The following is a description of a gene set: A SWI/SNF-type complex that is found in neural stem or progenitor cells, and in human contains actin and proteins encoded by the ARID1A/BAF250A or ARID1B/BAF250B, SMARCD1/BAF60A, SMARCD3/BAF60C, SMARCA2/BRM/BAF190B, SMARCA4/BRG1/BAF190A, SMARCB1/BAF47, SMARCC1/BAF155, SMARCE1/BAF57, SMARCC2/BAF170, PHF10/BAF45A, ACTL6A/BAF53A genes. The npBAF complex is essential for the self-renewal/proliferative capacity of the multipotent neural stem cells. Human Gene Set: GOCC_NPBAF_COMPLEX species: Homo sapiens, and this is the list of marker genes: ACTB, ARID1A, ACTL6A, SS18, SMARCB1, SMARCD3, SMARCD1, SMARCC2, SMARCA4, SMARCA2, SMARCE1, PHF10, ARID1B, SMARCC1 (NCBI Gene Id 6599)